The following is a description of a gene set: Catalysis of an oxidation-reduction (redox) reaction in which NADH or NADPH acts as a hydrogen or electron donor and reduces a hydrogen or electron acceptor. Mouse Gene Set: GOMF_OXIDOREDUCTASE_ACTIVITY_ACTING_ON_NAD_P_H species: Mus musculus, and this is the list of marker genes: Ncf2, Duox2, Noxa1 (NADPH oxidase activator 1), Ncf4, Pdgfb, Cyba, Ndufa2, Noxo1, Txnrd1, Ndufs8 (NCBI Gene Id 225887), Aifm1, Akr1c14, Dcxr, Cryz, Ndufs1, Ndufv2, Akr1c18, Mtrr, Dhrs4, Rtn4ip1, Miox, Por, Cyb5r3, Ndufs2, Cyb5r1, Nox1, Akr1c19, mt-Nd3, Ncf1, Sh3pxd2b, Cyb5r4, Nox3, Mical2, Cyb5r2, Aifm3, mt-Nd6, Cbr1, Ndufv1, Cox15, Nqo2, Aifm2, Fmo5 (NCBI Gene Id 99564), Ndufa9, mt-Nd5 (mitochondrially encoded NADH dehydrogenase 5), Adh4, Kmo, mt-Nd2, Ndufs4, Duox1, Cybb, Ndufs7, Sh3pxd2a, mt-Nd1, Ndufa10, Cbr1b, mt-Nd4l, Enox1, Ndufb7, Akr1c13, Nox4, Akr1c12, mt-Nd4, Akr1cl, Cyb5rl, Ndor1, Ambp, Akr1c21, Rnls (NCBI Gene Id 67795), Ndufs3, Mical1, Cbr4, Akr1c6, Cyp2j6, Akr1c20, Cbr3, Nqo1